The following is a description of a gene set: Genes predicted to be targets of miRBase v22 microRNA mmu_miR_6951_5p in miRDB v6.0 with MirTarget v4 prediction scores > 80 (high confidence targets). studied in species Mus musculus from publication Chen Y, Wang X (PMID 31504780) Mouse Gene Set: MIR_6951_5P, and this is the list of marker genes: Dis3, Csnk1g3, Skil, Wdfy3, Prdm8, Zfp750, Ghrh, Add3, Pola1, Fbxl3, Hspa14, Ptprd, Cdc42bpa, Ints6, Elovl7, Slc2a1, Kdm7a (lysine (K)-specific demethylase 7A), Rbpj, Htr2b, Lpp, Abhd17c, F830016B08Rik, Mat2b, Rasal2, Hyal6, Fuz, Cert1, Car10, Celsr2, Pnpla8, Txlnb, Spen (NCBI Gene Id 56381), Pbx1, Rnf150, Mgat4a, Far1, Rad51d, Atp2c1, Rarb, Atg4a, Fgf12, Ltbp3, Frmd3, Ccdc88a, Tlr4, Hadhb, Cabcoco1, Lyrm2, Matr3, Slc24a2, Mak16 (MAK16 homolog), Ggps1, Rb1, Trip12, Psd3, Hsp90aa1, Plekhm3, Usp14, Cxcl17, Spink5, Zfp449, Mtus1, Prkx, Pou3f2, Pgm3, Aoc3, Ldb3, Reg3a, Sptssa, Gpd1, Mosmo, Rabgap1l, Kcnj13, Pabpc1, Cnot7, Col11a1, Pax9, Adamts5, Nalcn, Zbtb10, Plpbp, Prlr, Cstf3, Chd6, Ubr3, Hnrnpa2b1, Fbxo30, Rlig1, 2300002M23Rik, Zbtb47, Cpne3, Fam174a, Dram1, Cnga3, Gsta5, Dleu7, Znrf3, Ncald (neurocalcin delta), Fstl5, Zbtb20, Itga8, Pi15, Ric3, Lrrc19, Col19a1, Elp4, Zc3h12c, Prnd, Epcam, Psmd14, Plat, Kctd12b (potassium channel tetramerisation domain containing 12b), D630045J12Rik, Sntg1, Sirt1, Nipsnap3b, H2bc6, Hoxa10, Siglecf (NCBI Gene Id 233186), Hormad1, Gpr4, Eif5a2, Tet1, Arid4a, B3galt5, Jcad, Frem1, Phc3, Vgll3, Krtap1-3, Nxpe4, Fga, Fstl4 (follistatin-like 4), Skint10, Polr2k (NCBI Gene Id 17749), Akr1d1, Fancl, Ccdc127, Lep, Tmem33, Tpp2, Aldh7a1, Amacr, Ecm2, Fam221a, Actr3b, Sav1, Szrd1, Pbrm1, Fign, Slc26a11, Tll1, Cog3, Msr1, Clvs2, Arid2 (AT-rich interaction domain 2), Tmed5, Lrrc49, Gnl3, Tmem263, Zfp704, Nexmif, Hdac9, Ugcg, Rora, Inpp4b, Dclre1c, Bcl2, Sim2, Invs, Prpf4b, Impg1, Syncrip, Fndc1, Scp2 (NCBI Gene Id 99990), Kcnc2, Gstt3, Arid1a, Zbtb34, Nrxn1, Pacsin1 (NCBI Gene Id 353072), Kdm6a, Psme1, Sall1, Nbeal1, Cdkl3 (NCBI Gene Id 213084), Med30, 5730455P16Rik, Snx1, Vcpip1, Parpbp, Il7r, Slc35d2, Nup153, Hmgb1, Gsk3b, Zfp57, Nfyc, Cwf19l2, Nufip2, Zfp326, Map1b, Zfp414, Ect2, Atp11c, Zic1, Dkk3, Rab33b, Elavl4, Atp13a3, Lrp6, Mmachc, Ggh, Gtf2a1, Polr1f, Rtl4, Prg4, Epm2aip1, Hebp1, Map2k6, Actrt1, Leo1, Insm2, Ap3m1, Cntn5, Ptrh2, Trpc6, Tsc22d2, Tfap2b, Rasef (RAS and EF hand domain containing), Spty2d1, Zfp148, Zhx1, Zfp963, Arl6ip5, Snrpf, Iqck, Fam171a2, Tubd1, Zfp292, Ppp2ca, Ankrd29, Usp12, Dcun1d1, Cacna1e, Dclk1, Nrg3, Usp9x, Atl2 (NCBI Gene Id 70260), Usp15, Ankrd12, Ccl28, Trappc9, Brpf3, Tmem131, Ppp3cb, Zbtb8b, Irx5, Bahcc1, Rab11fip1, Rundc3a, Aldoart1, Ccnb3, Sgo2a, Dbf4, Thsd4, Wapl, Msi2, Phf12, Uchl5, Kcmf1, Zfp748, Ints2, Sppl3 (NCBI Gene Id 83678), Crls1, Arpp19, Tcea3, Naf1, Fam178b, Tomm20, Ufl1, Dennd1b, Asf1a, Pcf11, Lama3, Klf8, Snx25, Zeb2, Fam169a, Sema5a, Dsg3, Marchf6, Prn, Pde1b, Rgs7bp, Nfia, Angptl1, Ambn, Ubap1, Picalm, Mpdz, Apold1, Svs3b, Pabir1, Ubxn7, Atp2b1, Rbm41, Rabl3, Lca5l, Mn1, Zfp260, Gabra4, Aqp9, Samd5, Gucy1a2, 2210408I21Rik, Mbd4, Fut9, Ccnl1, Cpeb4, Shisal2b, Ppp4r2, Gata2, Prdm2, Slitrk2, Cpa6, Aftph, Rpp14, Mbd5, Shtn1, Pcdh18, Ercc6l2, Zmym6, Gm14326, Ppp1r2, Zic3, Scn9a, Nrcam, Sst, Gli3, Klf6, Fam241a, Atxn7l3b (ataxin 7-like 3B), Neurod4, Chic2, Ppm1b, Mtor, Tbc1d12, Zyg11b, Cmc1, Ift81, Ahrr (aryl-hydrocarbon receptor repressor), Efcab7, Klhl23, Pten, Tlcd4, Thoc7, Zfp799, Kctd1, Kras, Tgfb3, Elavl2, Eif4g3, Mei4, Foxn3, Sim1, Fnip1, Sirt6, Stmn2, Mfap3l, Dmac2l, C1qtnf3, Acap2, Crebrf (NCBI Gene Id 77128), Dmrtc2, Gsta2, Kmt2a, Syt14, Rap2b, Fam171b (family with sequence similarity 171, member B), 2310009B15Rik, Tbc1d15, Gphn, Ddx46, Mbd3l2, Irf2bpl, Foxc1, Slco2b1, Ndufaf7, Chrdl1, Ddx5, Scn8a, Luc7l3, Gja8, Tnrc6b, H1f0, Kbtbd3, Abhd18, Suv39h1, Cimip2b, Cd46, Ccar2, Fgd4, Tasor2, N4bp2l2, Grip1 (NCBI Gene Id 74053), Paxbp1, Tmem245, Ap4e1, Homer1, Cdkn1b, Zfp873, Ikzf2